The following is a description of a gene set: A cell cycle checkpoint that detects and negatively regulates progression from G2 to M phase as part of a mitotic cell cycle. studied in species Mus musculus Mouse Gene Set: GOBP_MITOTIC_G2_M_TRANSITION_CHECKPOINT, and this is the list of marker genes: Inip, Plk1, Nbn, Cdc14b, Dtl, Taok1, Blm, Nae1, Rint1, D7Ertd443e, Nop53, Foxn3, Chek1, Mrnip, Babam2, Mre11a, Brca1, Ccng1, Hus1b, Cdc6, Brcc3dc, Nabp2, Ier3, Foxo4, Etaa1, Mbtps1, Rad17, Fzr1, Babam1, Topbp1, Taok2, Brsk1, Cdk1 (cyclin dependent kinase 1), Abraxas1, Cdkn1a, Syf2, Ticrr, Rbbp8, Uimc1, Cdk5rap3, Clspn, Nabp1, Donson, Atm, Orc1, Pabir1, Mbd4, Taok3, Rad50, Hus1, Mbtps2, Creb3l1, Atr, Bard1, Brcc3, Zfp830, Ints3, Trim39, Chfr